The following is a description of a gene set: electronically inferred by orthology from the curated human pathway part of: SLC-mediated transport of amino acids This event has been computationally inferred from an event that has been demonstrated in another species.<p>The inference is based on the homology mapping from PANTHER. Briefly, reactions for which all involved PhysicalEntities (in input, output and catalyst) have a mapped orthologue/paralogue (for complexes at least 75% of components must have a mapping) are inferred to the other species. studied in species Mus musculus Reactome Pathway: Amino acid transport across the plasma membrane, and this is the list of marker genes: Slc38a2, Slc36a4, Slc7a6, Slc6a19, Slc7a9, Slc1a4 (NCBI Gene Id 55963), Slc7a10, Slc38a3, Slc36a2, Slc16a10, Slc7a7, Slc3a2, Slc7a3, Slc7a8, Slc3a1